Given this list of marker genes LTC4S, CPSF3, IMPA1, FARSA, RNF135, ECI1, LDHB, SPRYD7, CBR4, NBR1, KMT2A, SYNJ2, TOP1 (DNA topoisomerase I), CCT3, LSM3, AARSD1, IGHM, PNPLA2, C7orf25, GOSR2, APPBP2, TXNRD2, ANGPTL4, EPHX1, C5orf22, CD274, SLC30A9, HNRNPDL, GLDC, GBP4, FBXO33, THAP2, CUTC, UTRN, NUP160, ECHDC1, SLAIN1, DHX57, DCAF12, RRP15, PSMB4, ERGIC1, FOXP1, METTL3, HSPB2, SRM, SLC25A3 (solute carrier family 25 member 3), NSMF, ATG3, TMEM42, RABL6, POT1, SKP2, ADSL, KRTAP3-1, NAB2, EBAG9, CD80, HMGCR, RP1, MRPL4, BLM, URI1, IL18RAP, SH3BP2, NUDT13, TRIAP1 (TP53 regulated inhibitor of apoptosis 1), ERMP1, MMAA, PLXNB2, UTP25, ZNF362, MRPL44, PSMB8, HMGN5, PLD1, NUB1, SLC37A1, PRRG2, PHLDB1, TEFM, CYP2C19, RIMOC1 (NCBI Gene Id 285636), GRAMD2B, RNPEP, ZBTB32, EIF3E, SMARCA5, MFSD4B, ERCC3, TMEM87A, MTREX, SENP6, ATP9B, TDRP, ZC3H8, COPS7A, GNL3, NOLC1, USP25, ATP9A, ZSCAN21, NUDCD2, ZNF292, FIS1, HDDC2, KDM6A (lysine demethylase 6A), PUS10, SLC13A3, IFNAR1, PEX3, IREB2, HSD17B10, CYP51A1, TOMM7, NLRX1, IRF2BP1, DGCR6, RAD51B, PPP4R3A, MAOA, TWIST2 (twist family bHLH transcription factor 2), FBXL15, NEK4, SDF4, DUSP2, HNRNPUL1, CCL4, TMCC2, REEP5 (receptor accessory protein 5), APOD, DALRD3, PYCARD, CCT2, AKR7A2, CHST15, JARID2, PHLDA1, EXOC6, MRPL42, KCNK10, DERA, NTRK3, UQCR10, CLPB, INPP5K, TSEN15, GPN1, MKKS, NNT, C8orf76, NDUFAF5 (NADH:ubiquinone oxidoreductase complex assembly factor 5), PFKFB1, ATP6V1A, CCL17, ELOVL6, STAT4, STK39, CD320, PSRC1, SERTAD2, EIF4E (eukaryotic translation initiation factor 4E), EFTUD2, RBPMS2, IL21R, EPM2AIP1, MTARC2, BMP8B, INTS14, PDK3, CCDC80, SLC4A3, MEF2D, IFNG, TAPBP, CFHR2, UBAC1, TNFSF14, SART3, CSNK1G1, NCF1, BCDIN3D, PPAN, ANAPC13, MCOLN2, GHITM, FUNDC1, YBX1, C8orf33, PALS2, ARF3, FEM1B, MGST1, IRF9, GALM, MTA1, DKK3, PPP4R3B, here is a description of the gene set: Genes down-regulated in IKZF1 knockout: hematopoietic stem cells versus lymphoid-primed multipotent progenitors. species: Homo sapiens Human Gene Set: GSE15330_HSC_VS_LYMPHOID_PRIMED_MULTIPOTENT_PROGENITOR_IKAROS_KO_DN from publication Ng SY, Yoshida T, Zhang J, Georgopoulos K (PMID 19345118) Regulation of lineage potential and transcriptional priming by Ikaros. New insight is provided into a bivalent regulation of lineage priming in the HSC and its lympho-myeloid restricted progeny the LMPP by the lymphoid lineage-determining factor Ikaros Whereas Ikaros is responsible for the activation of a cascade of lymphoid expression programs and for the establishment of lymphoid potential from the HSC to the LMPP it is also responsible for the repression of stem cell and erythroid genetic programs that are incompatible with further lineage restrictions emanating from the LMPP